The following is a description of a gene set: Mouse Gene Set: GOBP_REGULATION_OF_DEFENSE_RESPONSE_TO_FUNGUS species: Mus musculus Any process that modulates the frequency, rate or extent of defense response to fungus., and this is the list of marker genes: Usp15, Trim62 (NCBI Gene Id 67525), Pla2g5, Arg1, Fam3a, Pomc, Spi1, Cxcl1